The following is a description of a gene set: Any process that activates or increases the frequency, rate or extent of stem cell proliferation. Mouse Gene Set: GOBP_POSITIVE_REGULATION_OF_STEM_CELL_PROLIFERATION studied in species Mus musculus, and this is the list of marker genes: Fgf4, Bmp4, Fermt2, Tbx3, Taf4b, Mir320, Trp63, Vegfc, Prrx2, Fgf8, Ngf, Tial1, Ptprc (NCBI Gene Id 19264), Foxm1, Lrp6, Nr2e1, Tgfbr1, Tlx1, Hdac5, Kdr, Osr2, Sox11, Ltbp3, Thpo, Fgf10 (NCBI Gene Id 14165), Wnt5a, Shox2, Mir702, Epcam, Kitl, Wnt1, Sirt6, Hnrnpu, Prrx1, Cxcl1, N4bp2l2, Mir205, Ccne1, Setd1a, Fgf2, Hmga2 (NCBI Gene Id 77357), Hoxa3, Pdcd2, Prl2c3 (prolactin family 2, subfamily c, member 3), Gja1, Sox9, Wnt10b, Pax3, Fgf9, Pbx1, Runx2, Atxn1l, Tert, Dppa2, Gli2, Hmx2, Fgfr1, Tgfb1, Kat7, Fgfr2, Ell3, Tbx18, Ctnnb1, Kdm1a